The following is a description of a gene set: Human Gene Set: GOBP_ACTIVATION_INDUCED_CELL_DEATH_OF_T_CELLS A T cell apoptotic process that occurs towards the end of the expansion phase following the initial activation of mature T cells by antigen and is triggered by T cell receptor stimulation and signals transmitted via various surface-expressed members of the TNF receptor family such as Fas ligand, Fas, and TNF and the p55 and p75 TNF receptors. species: Homo sapiens, and this is the list of marker genes: AKT1, TGFB2, DNAJA3, IL2RA, RIPK3, TSC22D3, SIVA1, GPAM, FAS, FADD (NCBI Gene Id 8772)